Given this list of marker genes P4hb, P4htm, P4ha2, P4ha1, P4ha3, here is a description of the gene set: Catalysis of the reaction: procollagen L-proline + 2-oxoglutarate + O2 = procollagen trans-4-hydroxy-L-proline + succinate + CO2. species: Mus musculus Mouse Gene Set: GOMF_PROCOLLAGEN_PROLINE_4_DIOXYGENASE_ACTIVITY